Given this list of marker genes Kat5, Bag3, Zdhhc19, Hspb8, Csnk2a1, Htt, here is a description of the gene set: Any process that activates or increases the frequency, rate or extent of aggrephagy. Mouse Gene Set: GOBP_POSITIVE_REGULATION_OF_AGGREPHAGY studied in species Mus musculus